Given this list of marker genes MNS1, MEX3B, DMD, CMPK2, ZBTB8OS, IFTAP, VPS4B, DYNLL2, DGKG, MRTFA, MRPL51, SRP54 (signal recognition particle 54), TAFAZZIN, SMARCC1, NXNL2, DRG1, RMND5B, RNF130, HMGCR, YBX3, CENPO (centromere protein O), AIP, KNOP1, LYAR, XKR5, TRIM39, SLC22A4, COL9A2 (NCBI Gene Id 1905), PILRB, SKA3, GLIPR1, C4orf46, AVL9, PAXX, PPP2R5D, IRF9, HLCS, HDAC1, MAPK4, CITED2, STAT1, BAG4, SLITRK6, SLC16A14, SRSF5, GPD2, ZCRB1, ITPA, MGA, RAF1, ZBTB22, MLH1, SHMT1 (NCBI Gene Id 9316), SDC2, SLC48A1, RNF31, TIMP2, BAZ1A, FIS1, MRPS12, TMA16, POLE (DNA polymerase epsilon, catalytic subunit), THAP12, RGCC, RABGAP1L, AGO1, TCF3, AKAP7, MID1IP1, SPIDR, NOP56, PCMTD1, SPATS2L, VPS28, C1orf56, INCENP, ZNF768, NDUFB10, RHBDF2, CD81, AKT2, EBF1, SAFB, SLC32A1, NCOA6, BLCAP, APPBP2, VASP, PWWP2B, ZFP36L2, MYL2, ZW10, CEP44, FMNL3, TARS2, STRBP, CEP76, ARRB1, NDUFA13, TMBIM4, SON, NSMCE4A, RPL13A, LSM14A, MCEE, FAM193A, TRIM28, ATXN7L3B, BCL10, SNRPC (NCBI Gene Id 6631), PYCARD, MTG2, ITGB3BP, ELOF1 (elongation factor 1), MFAP2 (microfibril associated protein 2), PDAP1, MRPL44, ILRUN, FGD3, HERC1, PDE6D, COPZ1, SBNO1, ZNF445, MAT2A, ANKRD54, ARRDC4, ABCC4, BRD3, INPP4A, KHDC3L, RAD52 (NCBI Gene Id 5893), HSPBAP1, TIMM17B, SREBF2, ZFX, ARHGEF4, CORO1C, IFIT1, TYROBP, SELPLG, HBS1L (HBS1 like translational GTPase), MAX, AEBP2, STRN, TRAPPC6A, MCM7, SPTSSA, AURKB, CASP3, SUCO, CCNA2, PHKA2, GLOD4, HCST, CCDC115, IPMK, TFDP1, ITPK1, ARFGEF1, EMSY (EMSY transcriptional repressor, BRCA2 interacting), GOLGA1, EBI3, BHLHE40, CCDC47, FBXO42, CCT8, KIF2A, SSX2IP, CDC42SE1 (CDC42 small effector 1), GAPVD1, TXNIP, TIAM1, MAPK7, NDC1, TREML2, ANP32B, NDUFS4 (NADH:ubiquinone oxidoreductase subunit S4), CSNK1G2, RBM8A, SCRN3 (secernin 3), TSTD2, GAL, ADGRG3, ABCC5 (NCBI Gene Id 10057), TACC1, DOP1B, SMIM3, SGO2, GSDMD, CSF2RA, SDHA, HSD17B1, CD2BP2, INAFM1, PHKG2, CHIT1, KMT5B, ZNF518B, BBOF1, here is a description of the gene set: from publication Sanda C, Weitzel P, Tsukahara T, Schaley J, Edenberg HJ, Stephens MA, McClintick JN, Blatt LM, Li L, Brodsky L, Taylor MW (PMID 16800785) Type I and type II interferons (IFNs) bind to different cell surface receptors but activate overlapping signal transduction pathways. We examined the effects of a type I IFN (IFN-acon1) and a type II iFN (IFN-g1b) on gene experession in A549 cells and demonstrate that there is a common set of genes modulated by both IFNs as well as a set of gene specifically regulated by each, reflecting the activation of different signaling pathways. In particualr, IFN-g induced many more genes of the signaling pathways, apoptosis, and cytokine interactions than did IFN-a. Even with genes induced by both IFNs there were distinctive quantitativive differences in expression. IFN-g1b plays a major role in the induction and regulation of the complement pathway. Previous work has shown a synergistic antivral and antiproliferative effect of type I and type II IFNs in cell culture and in the treament of tumors in mice. We demonstrate that a majority of genes showed and additive effect of IFN-acon1 and IFN-g1b, but a subset of gene is synergistically induced; these incluce ISG10, MX2, OAS2, and other genes known to be involved in the antiviral response, TRAIL (TNFSF10) and caspases involved in apoptosis and chemokine genes RANTES, CXCL10, and CXCL11. Greater than additive transcription of some of these genes in the presence of both IFNs was confirmed by real-time kinetic RT-PCR. Elevated induction of many of these genes may be sufficient to explain the synergistic antiviral and antitumor effects of this combination of IFNS in vivo. Human Gene Set: GSE5542_IFNG_VS_IFNA_AND_IFNG_TREATED_EPITHELIAL_CELLS_24H_UP Genes up-regulated in epithelial cells (24h): IFNG versus IFNG and interferon alpha. species: Homo sapiens